The following is a description of a gene set: Mouse Gene Set: GOBP_REGULATION_OF_T_CELL_COSTIMULATION Any process that modulates the frequency, rate or extent of T cell costimulation. species: Mus musculus, and this is the list of marker genes: Ephb6, Cd160, Ephb4, Tnfsf4, Ccr7, Lilrb4a, Lilrb4b (leukocyte immunoglobulin-like receptor, subfamily B, member 4B)